Given this list of marker genes Dbi, Ins2, Bscl2, Adra2a, Hcar1, Pde3b, Il1b, Adora1, Akt1, Acacb, Etfbkmt, Cidec, Mfsd2a, Alk, Gpld1, Apoa2, Hcar2, Apoc3, Gimap3, Cidea (NCBI Gene Id 12683), Crtc3, Endou, Plin5, Cnr1, Pik3cg, Fmc1, Prkaa1, Ins1, Gimap5, Sorl1, Apoc1, Tnf, here is a description of the gene set: studied in species Mus musculus Any process that stops, prevents, or reduces the frequency, rate or extent of the chemical reactions and pathways resulting in the breakdown of lipids. Mouse Gene Set: GOBP_NEGATIVE_REGULATION_OF_LIPID_CATABOLIC_PROCESS